Given this list of marker genes DMPK, INMT, PLA2G6, DPH5, TNRC18, RILPL2, DENND2B, NCK2, USP44, FAM20A (NCBI Gene Id 54757), MBNL1, UBXN8, MRPL34, SYNE3 (spectrin repeat containing nuclear envelope family member 3), CYB5RL, RHOF, CDKN2D, RARG, SPATA33, AVPI1, OGN, PLEKHB1, GPRC5A, CTSD, SSTR4, TRIM16, TGIF2, KIF5B, CPSF4, CYP2D6, HIF1AN, SLC25A51, SHPK, RARB, AHCTF1, CCND1, UCK1, LTBP3, CTNS, HOXD12, RAMP2, CHMP1A, FBLN2, POLR3H, CARD10, CHKA, PPM1L (NCBI Gene Id 151742), DST, CALU, TPST2, ECHDC3, SHC1, SLC25A28 (solute carrier family 25 member 28), CFL2, CALR, PDGFD, MAP2K5, CLPP, F11R, WNT1, SLC25A24, H2BC5, PDLIM2, ATP11A, G6PD, IFFO2, MATN3, PARP3, PRSS30P, NDUFB10, HGFAC, TRMT61A, TUBB6, NDUFB8, ZNF574, KITLG, LSP1, DPP9, PALMD, EREG, NUDT6, WNK4, YAP1, GSR, IL34, CCN2, RESF1, AGPAT1, SNRNP35, STK11, METRN, MAPK13, PSMD12, AP2A2, IDO2, WWTR1, USP6NL, MMP2, NVL, GJB4, ZNF438, PLAGL2, BHLHE40, ITIH2 (NCBI Gene Id 3698), CLEC9A, CERS2, SRC, PITPNM2, AOC2, PITX1, IFI27 (NCBI Gene Id 3429), GRIK5, CP, BTN1A1, FTH1, LIPE, CTTN, MLLT6, DUSP14, AMPD2, SQSTM1, PCNX4, SLC25A4 (solute carrier family 25 member 4), NRP1, MIDN, LOXL2, TMEM179, DDIT3, RILP, SAT1, EVX2 (NCBI Gene Id 650617), LNX2, OMP, CRABP2, PKM, LTBP1, DGAT1, SGK1, UBC, ME3, DMWD, USPL1, ST3GAL3, CPA1, IDH3B, CEP95, PTTG1IP, SLURP1, SKIL, LRP1, PRSS8, HOXA13, PMM2, SH3BP1 (NCBI Gene Id 84161), HOXD13, JUNB, RHOD, TIRAP, TNFRSF11B, SERINC5, PCOLCE, AOX1, MED9, TOP2B (DNA topoisomerase II beta), CNIH4, SIRT6, GDE1, SLC39A13, CLNK, RLIM, COA3, SPART (NCBI Gene Id 23111), RIN2, TNFRSF12A, DUSP1, H1-10, THRSP, OSR1, DDX5, SPSB2, RNF5, FCHO2, RAB30 (NCBI Gene Id 27314), TAGLN2, DPYSL3, S100A8, SYT8, ANXA1, UBE2C, CLCF1, DBNDD1, CACNB1, DUSP4, OSBPL2, TIMP3, ABCB8, PGPEP1, HPDL, ZNF319 (zinc finger protein 319), PYURF, CCDC124, FSTL1, RPL10A, NDUFA4, TPM2, INPPL1, BCL2L11, ALS2CL, FTL, ROCK2, TNFSF13, HMGA1 (high mobility group AT-hook 1), PKN1, NID2, TSPAN9, H1-2, SNTB2, REX1BD, FGFR2, PLCD3, MRPL37, EMP1, ALKBH7, FIGN (fidgetin, microtubule severing factor), PITPNC1, MSLN, IL1RN, OLFML2A, PARK7, RPL13A, DEDD, GDF15, DDX24, ANKRD24, CSDC2, PPL, GAS2, ADO, TCIRG1, GPR146, MPV17L2, ARHGEF19, ANXA9, MRGPRF, EPHB2, RPL3L, LAMC1, DOK4, AEBP1, CTSB, NUPR1, RUFY1, OSBPL3, DNAJC17, GDPD5, AQP5, EFCAB2, PDLIM4, BAALC, CEBPB, NR1D1, DNM1, JRK, TNFRSF9, RFX1, NBL1, RHOQ, GJB5, ACADM, C1QTNF1, FAM107B, TYK2, TGFB3, ATXN2, CAVIN4, CTBP2, FN1, ZBP1, GLIS2, GAS8 (growth arrest specific 8), ESD, MAST2, FGF18, ARSA, IRF2BPL, PRX, CCP110, ADD3, ALDH3A1, PDLIM7, TNS2, CAPN5, ZNRF2, BSG, HOOK2, CA12, RRP1, S100A4, SLC35D1, STUB1, TRAF3IP2, ZNF474, TM4SF1, LOXL1, RCBTB2, RNF139, ITGBL1, FAIM2, MBD6, RHOBTB3, DUSP6, RPL19, DMP1, BLNK, GABARAPL1, SPTBN1, PSCA, PHYHD1, KLHL24, SUN2, RND3, COQ10B, OXNAD1, HOXA10, S100A3, CNTD1, RB1CC1, INF2 (NCBI Gene Id 84800), TCP11L2, TCTN1, SMAD6, COL1A1, PTPRS, PIGT, PEX2, VEGFA, DHRS3, FURIN, LCTL, FSCN1, NEK2 (NCBI Gene Id 4751), EPS8L2, IFRD1, PIK3R2, HHATL, WNT10B, RHOC, PICK1, SULF1, MMAA, RRAS, NDUFS8, EFNA1 (ephrin A1), CAPNS1, SCAF1, NID1, TMEM127, NRN1, CKB, PLSCR1, FUBP1, OTUD5, PIDD1, RHOBTB2, PRSS22, NDFIP1, here is a description of the gene set: Human Gene Set: DELACROIX_RARG_BOUND_MEF from publication Delacroix L, Moutier E, Altobelli G, Legras S, Poch O, Choukrallah MA, Bertin I, Jost B, Davidson I (PMID 19884340) Genes with DNA sequences bound by RARG in MEF cells (embryonic fibroblast). All-trans retinoic acid (RA) induces transforming growth factor beta (TGF-beta)-dependent autocrine growth of mouse embryonic fibroblasts (MEFs). We have used chromatin immunoprecipitation to map 354 RA receptor (RAR) binding loci in MEFs, most of which were similarly occupied by the RAR alpha and RAR gamma receptors. Only a subset of the genes associated with these loci are regulated by RA, among which are several critical components of the TGF-beta pathway. We also show RAR binding to a novel series of target genes involved in cell cycle regulation, transformation, and metastasis, suggesting new pathways by which RA may regulate proliferation and cancer. Few of the RAR binding loci contained consensus direct-repeat (DR)-type elements. The majority comprised either degenerate DRs or no identifiable DRs but anomalously spaced half sites. Furthermore, we identify 462 RAR target loci in embryonic stem (ES) cells and show that their occupancy is cell type specific. Our results also show that differences in the chromatin landscape regulate the accessibility of a subset of more than 700 identified loci to RARs, thus modulating the repertoire of target genes that can be regulated and the biological effects of RA. species: Mus musculus